Given this list of marker genes Ace, Furin, Cpe, Hagh, Cpa4, Ggt5, Lancl1, Adamts13, Anpep, Ggt1, Slc7a11, Tpp1, Lta4h, Dmd (NCBI Gene Id 93863), Tapbp, Nod2, Cpd, Lancl3, Eif2ak3, Ece1, Ide, Aebp1, Pcsk1, Abcb9, Npepps, Elane, Cryaa, Bdh2, Gclc, Cpq, Mmp7, Mgst2, Ggt7, Cpn1 (NCBI Gene Id 93721), Enpep, Ggt6, Cpm, Naaladl1, Lnpep, Lgals4, Mipep, Cpz (carboxypeptidase Z), Mme, Nln, Klk1b1, Slc1a2, Erap1, Nfe2l2, Bloc1s6, Pcsk5, Thop1, Pam, Slc1a1, Gss, Trhde, Lancl2, Ctsh, Aasdh, Gclm, here is a description of the gene set: species: Mus musculus The chemical reactions and pathways involving peptides, compounds of two or more amino acids where the alpha carboxyl group of one is bound to the alpha amino group of another. Mouse Gene Set: GOBP_PEPTIDE_METABOLIC_PROCESS